The following is a description of a gene set: studied in species Mus musculus Mouse Gene Set: GOBP_CYTOSOLIC_TRANSPORT The directed movement of substances or organelles within the cytosol., and this is the list of marker genes: Dennd5a, Mon2, Arfip1, Sybu, Bltp3b (bridge-like lipid transfer protein family member 3B), Gosr1, Pheta1, Rcsd1, Ap1ar, Slc66a2, Magel2, Ykt6, Snx32, Lamp1, Arl8b, Kif5b, Plekhj1, Snx8, Rufy1, Dennd2a, Klhl20, Sort1 (NCBI Gene Id 99747), Trim46, Baiap3, Mecp2, Snx6, Gbf1, Gga1, Usp7 (NCBI Gene Id 98021), Snx1, Arl1, Tbc1d10b, Bet1l, Rhobtb3, Prepl, Tmem87a, Srsf10, Rab4b, Cltc, Spag9, Stx5a, Gak, Rab29, Tmem87b, Laptm5, Golt1a, Ap4m1, Evi5, Tbc1d23, Slc30a6, Tbc1d10c, Syt4, Vps50, Vps26b, Actr2, Syt7, Wipi1, Arfrp1, Tpcn2, Tbc1d5, Snx5, Ap1g1, Vamp3, Eps15, Ube2o, Heatr5a, Atp9a (NCBI Gene Id 11981), Gcc2, Ap1s1, Kif1c, Dctn1, Sys1, Vps35 (NCBI Gene Id 65114), Golt1b, Trim27, Washc1, Mapk8, Cln5, Snx3, Ehd3, Map2, Sgsm2 (NCBI Gene Id 97761), Wipf3, Rab7, Lrrk2, Tbc1d17, Rab14 (RAB14, member RAS oncogene family), Kif1b, Erc1, Vps29, Vps51, Kif1a, Snx2, Vps52, Eipr1, Vps54, Rbsn, Dop1b, Washc2, Plekha3, Heatr5b, Stx6, Ankfy1, Rab6b, Tbc1d10a (TBC1 domain family, member 10a), Vti1b, Pheta2, Kif16b, Snx12 (sorting nexin 12), Vps26a, Ap5z1, Cln3, Rgp1, Rab6a, Pikfyve, Coro7, Ccdc91, Ppfia2, Kif5a, Pip4k2a, Ric1, Rab9b, Dop1a, Rab9, Trappc10, Rnf126, Vps53, Rab7b, Tbc1d14, Stx16, Tanc2, Vti1a